Given this list of marker genes Rsad2, Dph3, Uts2, Adra2a, Fkbp1b, Acvr1c, Foxo1, Pde1c, Sfrp1 (secreted frizzled-related protein 1), Psmd9, Erp29, Ffar3, Syt4, F2rl1, Adtrp, Kcnj6, Inhbb, Ptger3, Vsnl1, Ghsr, Srebf1, Midn, F2r (NCBI Gene Id 218465), Abcc8, Rhbdf2, Ghrl, Ins1, Gnao1, Fam3d (FAM3 metabolism regulating signaling molecule D), Cd200, Pde3b, Hadh, Idua, Hmgcr, Mup11, Ifnb1, Srcin1, Drd3, Neo1, Jagn1, Ccn3, Mup1, Nos1, Drd4, Drd2, Kcnb1, Gnai1, Rhbdf1, Pde4c, Idh2, Ins2, Rab11fip3, Anxa1, Npff, Mtnr1b, Pim3, Il1b (NCBI Gene Id 16176), Sergef, Ppp3ca, Kcnq1, Rab11fip5, Sirt4, Il12a, Oprm1, Kcnj11, Fbn1, Pfkl, Madd, Gnaz, Map4k4, Irs1, Cyp51, Ptpmt1, Eny2, Chga, Ptpn11, Anxa5, Ffar2, Prkn, Mup4, Tbc1d1, Rab11fip1, Mtnr1a, Ptprv, Rptor, Ucp2, Mup5, Mup2, Sytl4, Rest, Klf7, Il12b, Pde8b, Apoe, Frmd4a, Crhr2, Mup3, Ndufaf2, Nr1h3, Stxbp5l, here is a description of the gene set: Mouse Gene Set: GOBP_NEGATIVE_REGULATION_OF_PROTEIN_SECRETION Any process that stops, prevents, or reduces the frequency, rate or extent of the controlled release of a protein from a cell. species: Mus musculus